Given this list of marker genes Phb2, Ndn, Ddx39b, Yy1, Nufip1, Enc1, Runx1t1, Akap8, Blm, Brd7, Iffo1, Xpot, Ercc8, Dnmt3a, Psma6, Phf5a, Cad, Stag2, Tcerg1, Pola1, Cfl2 (cofilin 2, muscle), Nono, Krt8, Cebpb, Atxn7, Prkcd, Numa1, Ghrhr, Akap8l, Krt18, Lmna, Sfpq, Atf6b (NCBI Gene Id 54136), Arid2, Ahctf1, Fos, Cenpf (centromere protein F), Hnrnpm, Sorbs1, Tgfb1i1, Morc2b, Arfgef1, Chmp1a, Anp32a, Smarce1, Matr3, Kat8, Atn1, Morc3, Smarcb1, Trp53, Zfp326, Pbrm1, Dcaf7, Hat1, Cask, Stag1, Hnrnpu, Tenm1, Gfi1, Lmnb1, Smarcc2, Maea, Clic4, Sparc, Uhrf1, Btbd35f1 (NCBI Gene Id 71847), Cxxc1, Ppig, Hltf, Ruvbl2, Phactr3 (phosphatase and actin regulator 3), Gfi1b, Vdr, Csnk2b, Scaf8, Paxip1, Cfl1 (NCBI Gene Id 12631, cofilin 1, non-muscle), Actl6b, Dgkq, Nsmf, Atxn3, Smarca4, Hnrnpa2b1, Gmcl1, Rad21, Pias4, Phf10, Pspc1 (paraspeckle protein 1), Hlcs, Zfp703, Atxn1, Cebpa, Actb, Sf3b1, Lrif1, Prkcz, Smarcd1, Srrm1, Dntt, Satb2, Hes1, Mat1a, Ncor2, Smc1a, Vim, Ruvbl1, Snw1, Satb1, Prpf40a, Npm1, Alox5, Anxa2, Men1, Smc3, Actl6a, Basp1, Kin (Kin17 DNA and RNA binding protein), Srpk1, Smarcc1, Smarcd2, Rnasel, Thoc1, Cenpw, Fign, Pml, S100a10, Ogg1, Sptbn4, Mbd1, Tep1, Morc2a, here is a description of the gene set: Mouse Gene Set: GOCC_NUCLEAR_MATRIX A dynamic, proteinaceous framework within the nucleus of eukaryotic cells, composed of proteins and RNA, that provides structural support for chromatin organization, gene regulation, and nuclear processes. studied in species Mus musculus